The following is a description of a gene set: Genes positively differentially expressed in cell type: Langerhans upon treatment with cytokine: IL-2 in mouse lymph nodes in vivo. species: Mus musculus Mouse Gene Set: CUI_LANGERHANS_IL2_RESPONSE_UP from publication Cui A, Huang T, Li S, Ma A, Pérez JL, Sander C, Keskin DB, Wu CJ, Fraenkel E, Hacohen N (PMID 38057668) Cytokines mediate cell-cell communication in the immune system and represent important therapeutic targets. A myriad of studies have highlighted their central role in immune function, yet we lack a global view of the cellular responses of each immune cell type to each cytokine. To address this gap, the authors created the Immune Dictionary, a compendium of single-cell transcriptomic profiles of more than 17 immune cell types in response to each of 86 cytokines (>1,400 cytokine-cell type combinations) in mouse lymph nodes in vivo. A cytokine-centric view of the dictionary revealed that most cytokines induce highly cell-type-specific responses. For example, the inflammatory cytokine interleukin-1β induces distinct gene programmes in almost every cell type. A cell-type-centric view of the dictionary identified more than 66 cytokine-driven cellular polarization states across immune cell types, including previously uncharacterized states such as an interleukin-18-induced polyfunctional natural killer cell state., and this is the list of marker genes: Pfn1, Stat1, H2-T23, Cd74, Cst3